Given this list of marker genes FNDC3A, NR5A2, NR0B1, INHBA, NTRK1, RARA, ABCB1, SAFB2, SOX9, ATRX, FLNA, RAB13, ARID4B, GATA1, DMRT1, NR5A1, SOX8, WNT4, SCX, FER, NUP210L, FSHR, TCF21, ARID4A, HSD17B4, here is a description of the gene set: species: Homo sapiens Human Gene Set: GOBP_SERTOLI_CELL_DIFFERENTIATION The process in which a relatively unspecialized cell acquires specialized structural and/or functional features of a Sertoli cell. A Sertoli cell is a supporting cell projecting inward from the basement membrane of seminiferous tubules.